Given this list of marker genes SLC26A6, PCMTD2, ETS2, ADD1, ERBB3, TRIM31, PRRC2A (proline rich coiled-coil 2A), HUWE1, PABPN1, TNPO2, MTA1, KDM5C, REPIN1, RPL37A, PROSER1, ATP7B (ATPase copper transporting beta), CDK5RAP3, RPL18, SRRM2 (serine/arginine repetitive matrix 2), ERAL1, SCAF4, STX16, HOXB5, MPHOSPH8, CDK16, EPHB2 (EPH receptor B2), CLCN7, NPIPB3, ENGASE, ZNF263, SPOP (speckle type BTB/POZ protein), HGH1, GRINA, BRD1, DDX11, ZFP36L1, RAB15, MED14, PTCH1, ECHDC2, RCBTB1, FMR1, ZNF518A, ZP3, STX3, AKAP17A (NCBI Gene Id 8280), ZNF652, LRP6, NPIPA1, F8A1, OGT, CCDC9, APBB3, ZNF767P, SFPQ, ALDH7A1, DLGAP4, PIGL, PHF8, NIPSNAP3B, ACVR1B, SIN3B, INPP5D, ELMO2, MED12, PHKB, KATNB1, ARHGAP8, NFATC2IP (NCBI Gene Id 84901), ATN1, KHSRP, SMARCC2, GABRE, CCNJ, FBXO46, UPF3A, CPNE1, POLR1HASP, ASXL1, PEX5, SH2B1, GFOD1, NEK3, GTF2IRD1, NPEPPS, here is a description of the gene set: studied in species Homo sapiens from publication Laiho P, Kokko A, Vanharanta S, Salovaara R, Sammalkorpi H, Järvinen H, Mecklin JP, Karttunen TJ, Tuppurainen K, Davalos V, Schwartz S Jr, Arango D, Mäkinen MJ, Aaltonen LA (PMID 16819509) Serrated colorectal carcinomas (CRCs) are morphologically different from conventional CRCs and have been proposed to follow a distinct pathway of CRC formation. Despite studies of single molecular events in this tumor type, the diagnosis of serrated CRC relies on morphology and the putative unique biological character of these tumors has not been established. Here we show that the gene expression profiling of 37 CRCs separated serrated and conventional CRCs into two distinct branches in unsupervised hierarchical clustering (P-value 7.8 x 10(-7)), and revealed 201 differentially expressed genes representing potential biomarkers for serrated CRC. Immunohistochemistry was utilized to verify the key findings in the 37 CRCs examined by expression profiling, and a separate validation set of 37 serrated and 86 conventional CRCs was examined to evaluate the candidate biomarkers in an extended sample material. Ephrin receptor B2, hypoxia-inducible factor 1-alpha and patched appeared as proteins important for genesis of serrated CRC. This study establishes serrated CRCs as a biologically distinct subclass of CRC and represents a step forward in the molecular classification of these cancers. The study also provides a platform to understand the molecular basis of serrated CRC and in long term may contribute to the development of specific treatment options for this tumor type. Genes down-regulated in serrated vs conventional colorectal carcinoma (CRC) samples. Human Gene Set: LAIHO_COLORECTAL_CANCER_SERRATED_DN